Given this list of marker genes CRYM, IL1RL1, PABPC4, IRF8, ITM2A, HSPA1L, KCNK2, FBXO11, PDGFRA, A2M, CD69, HSPA8, WNT5A, LUM, PARD3, HSPA2, PPP1R3F, IL1RAP, LCP2, CCND1, EGR1, CDH1, here is a description of the gene set: Genes down-regulated in MDA-MB-231 cells (breast cancer, mutated TP53) undergoing aberrant mitosis and necrosis after treatment with 2 nM docetaxel. Human Gene Set: HERNANDEZ_ABERRANT_MITOSIS_BY_DOCETACEL_2NM_DN species: Homo sapiens from publication Hernández-Vargas H, Palacios J, Moreno-Bueno G (PMID 17099726) Among microtubule-targeting agents, docetaxel has received recent interest owing to its good therapeutic index. Clinical trials have underlined its potential for the treatment of advanced breast cancer, although little is known about its molecular mode of action in this context. We characterized the molecular changes induced by docetaxel in two well-known human breast carcinoma cell lines. Two mechanisms of action according to drug concentration were suggested by a biphasic sensitivity curve, and were further validated by cell morphology, cell cycle and cell death changes. Two to four nanomolar docetaxel induced aberrant mitosis followed by late necrosis, and 100 nM docetaxel induced mitotic arrest followed by apoptosis. Passing through mitosis phase was a requirement for hypodiploidy to occur, as shown by functional studies in synchronized cells and by combining docetaxel with the proteasome inhibitor MG132. Transcriptional profiling showed differences according to cell line and docetaxel concentration, with cell cycle, cell death and structural genes commonly regulated in both cell lines. Although p53 targets were mainly induced with low concentration of drug in MCF7 cells, its relevance in the dual mechanism of docetaxel cytotoxicity was ruled out by using an isogenic shp53 cell line. Many of the genes shown in this study may contribute to the dual mechanism by which docetaxel inhibits the growth of breast cancer cells at different concentrations. These findings provide a basis for rationally enhancing docetaxel therapy, considering lower concentrations, and better drug combinations.